Given this list of marker genes Hgf, Gab1, Grb2, here is a description of the gene set: Reactome Pathway: MET activates PI3K/AKT signaling species: Mus musculus part of: Signaling by MET electronically inferred by orthology from the curated human pathway This event has been computationally inferred from an event that has been demonstrated in another species.<p>The inference is based on the homology mapping from PANTHER. Briefly, reactions for which all involved PhysicalEntities (in input, output and catalyst) have a mapped orthologue/paralogue (for complexes at least 75% of components must have a mapping) are inferred to the other species.